The following is a description of a gene set: Mouse Gene Set: GOMF_DNA_BINDING_TRANSCRIPTION_FACTOR_ACTIVITY A transcription regulator activity that modulates transcription of gene sets via selective and non-covalent binding to a specific double-stranded genomic DNA sequence (sometimes referred to as a motif) within a cis-regulatory region. Regulatory regions include promoters (proximal and distal) and enhancers. Genes are transcriptional units, and include bacterial operons. species: Mus musculus, and this is the list of marker genes: Nr1d2, Esx1, Hoxd13, Neurod6, Hivep3, Sohlh2, Hivep1, Hoxa13, Ppara, Foxn4, Zfp266, Erg, Sox12, Aebp1, Smad3, Gli2, Hoxb6, Zfp296, Pbx1, Figla, Prdm16, Zfp182, Zfp772, Zfp941, Klf2 (NCBI Gene Id 16598), Isl1, Rslcan18, Zeb1, Foxe3, Pparg, Rhox2c, Twist1, Zhx1, Dlx1, Six3, Pbx3, Zscan29, Pou3f4 (POU domain, class 3, transcription factor 4), Csrnp1, Zfp442, Usf1, Rbpjl, Zfp451, Rfx5, AI854703, Hoxa11, Zbtb7c, Sox13, Myef2 (myelin basic protein expression factor 2, repressor), Gtf2i, Zfp729a, Zbtb25, Tbx6, Sp2 (NCBI Gene Id 78912), Relb, Zfp935, Rxrb, Scx, Cebpd, Olig3, Bhlha9, Zfp87, Hesx1, Mef2c, Hoxd10, Alx1, Tead4, Snai2, B020011L13Rik, Zfp148, Tcf7l1, Zfp872, Lbx1, Lef1, Arid3c, Zfp518a, Ar, Zfp395, Ovol3, Sp8, Onecut1, Elf2, Nfatc1, Hmx1, Zfp696, Pgr, Purg, Zfp322a, Nfe2 (nuclear factor, erythroid derived 2), Tcerg1, Ecsit, Irf2, Mnt, Dach1, Mecom, Pou3f1, Zfp472, Rela, Litaf, Uncx, Zfp973, Zfp773, Zfp1007, Ebf3 (NCBI Gene Id 73115), Bach1, Zfp790, Trp63, Gm10033, Batf3, Crebl2, Nr6a1, Foxc2 (NCBI Gene Id 14234), Zfp982, 4930522L14Rik, Fezf1, Zfp174, Atf5, Nr5a2, Zfp950, Esrrg, Tcf3, Zfp747, Rhox1, Rhox3g, Neurog1, Nkx2-6, Egr2, Sohlh1, Zeb2, Ikzf3, Neurog2, Stat6, Nkx6-1, Ebf1, Osr1, Tfe3 (transcription factor E3), Gm14443, Tead3, Hif3a, Mycl, Gm14322, Zic4, Zfp2, Zfp871, Preb, Hand2, Mycs, Prdm5, Klf1, Zfp784, Dmrta2, Zfp710, Gm19965, Zfp39, Smad9, Zfp110, Rfx7, Stat5a, Atf2, Ncoa3, Gm14418, Myog, Zim1, Dmrtc1a (NCBI Gene Id 75663), Drgx, Onecut3, Mxi1, Satb2, Sim2, Zfp566, Zfp692, Foxo3 (NCBI Gene Id 97633), Runx1, Zfp24, Zfp764, Dmtf1l, Sox8, Zfp712 (NCBI Gene Id 78251), Zscan26, Meox1 (mesenchyme homeobox 1, NCBI Gene Id 17285), Kmt2d, Klf16, Zbtb1, Gm17655, Msx2, Foxn3, Zfp369, Phox2b, Zbtb2, Duxf4, Hsf2, Zfp189, Etv3, Gcm1, Thap1, Glis3, Sall2, Gli3, Zfp534, Sall1, Pou3f2, Foxh1, Stat2, Vsx1, Rpf2, Foxg1, Rfx8, Zfp456, Satb1, Nacc1, Zfp980, Zfp791, Klf14, Cdc5lrt10, Ascl2, Zfp184, Pou4f2, Zfp317, Aff1, Nr1h5 (NCBI Gene Id 381463), Gpbp1, Zfp683, Carf, Bnc1, Zfp382, Gsx1, Shox2, Zbtb4, Lhx4, Zscan10 (zinc finger and SCAN domain containing 10), Ets2, Sp110, Cc2d1b, Zfp524, Tcf23 (transcription factor 23), Ctcf, Tlx1, Rhox7b, Samd11, Sry, Zbtb3, Rbpj, Zfp560, Meis1, Obox1, Spz1, Zscan4-ps1, Isx, Zfp287, E4f1, Zbtb9, Irf7, Rxrg, Plag1, T, Zfp998, Zfp9, Foxl3, Thra, Zfp934, Mef2b, Zfp729b, Zfp423, Zfhx3 (zinc finger homeobox 3), Foxd3, Zfp992, Prrx2, Irf8, Otx1, Hdac5, Zkscan5, Esrra, Tbx5, Sp140l1, Zfp438, Zfp160 (NCBI Gene Id 77146), Zfp14, Zfp607a, Gm3604, Zic1, Obox2, Zfp979, Ets1, Zfp1, Purb, Prrx1, Zfp58 (NCBI Gene Id 238693), Atf6b, Dbx1, Otx2, Creb3l2, Rreb1, Jdp2, Nfix, Zfp930, Tfap2e, Rarg, Rsl1, Neurod4, Nr3c1, E2f2, Hoxc4, Skil, Sp140l2 (Sp140 nuclear body protein like 2), Foxe1, Sox30, Pou6f1, Plscr1, Nkx6-3, Zfp101, Zfp68, Bcl11a (BCL11 transcription factor A), Trps1, Zfp641, Dmrt1, Notch2, Zkscan17, Samd7, Zfp386, Zfp981, Lhx1, Lhx6, Egr3, Zfp758, Gata4, Pura, Junb, Zfp507, Barhl1, Zfp746, Hoxa7, Gm14434, Sox15, Zik1, Npas4, Vax2, Rhox11, Foxk2, Helt, Ikzf4 (NCBI Gene Id 319294), Crxos, Cebpg, Zfp966, Sox6, Mesp1, Zfp867, Mafk, Mypop, Tgif2, Sp4, Zfp563, Pasd1, Sp3, Zfp740, Obox8, Tfdp2, Gata6 (NCBI Gene Id 14465), En2, Zfp582, Mxd1, Pax5, Myrfl, Cphx1, Nkrf, Nkx2-3, Epas1, Tfec, Sp6, Zscan4c, Sox4, Zfp667, Insm1, Hlx, Prdm1, Zscan4d, Tshz2, Ski, Sox14, Zfp273, Zfp819, Nfyc, Gm14325, 2810021J22Rik, Tbx4, Thrb, Zfp105, Zfp239, Rel, P2rx2, Creb3, Fezf2, Zkscan16, Fosl1, Zfp551, Cdx2, Usf3, Zfp637, Dmrt2, Tbx21, Zfp146, Egr1, Vdr, Sall3, Zbtb10, Dbp, Zfp946, Pitx3, Hif1a, Nrf1, Dlx2, Zfp512b, Nkx6-2, Nr1h2, Prdm11, Nfkb2, Rhox3a, Klf10, Olig2, Prdm2, Bmal1, Zfp446, Foxf1, Ebf4, Foxr1, Skor1, Zfp1004, Smad2, Dmrta1, Sox2, Zfp623, Zbtb46, Zfp280b, Tcf7, Gata2, Creb1, Zfp354b, Mnx1, Zfp697, Lbx2, Mixl1, Atf4, Foxp4, Nr4a2, Nkx1-2, Ascl4, Irf6, Zbtb47, Patz1, Rhox4b, Nkx2-2, Hoxa2, Zfp513, Zfp952, Gm6871, Hoxa4, Zfp516, Bhlhe40, Klf17, Zfp213, Zkscan1, Hoxb3, Npas3, Hdx, Sox10, Atf6, Zfp971, Ahr, Gm14403 (NCBI Gene Id 433520), Zfp763, Zfp212, Tfcp2l1, Meis2 (NCBI Gene Id 319479), Zfp169, Zfp985, Foxl1, Zfp384, Batf2, Irx1, Zscan4e, Barx2, Mkx, Zfp963, Hoxb2, Bmal2, Myrf, Zfp418, Zc3h8, Irf5, Zfp870, Zbtb11, Arnt, Cdc5lrt5, Zfp41, Zfp954, Zfp959, Zbtb14, Gm4767, Jun, Alx4, Zfp28, Xbp1, Zbtb40, E2f7, Foxj2, Nfe2l3, Foxs1, Foxq1, Nr1h4, Jph2, Irf3, Rhox4c, Zfp644, Zbtb6, Or51e2, Hmx3, Arap1, Pou5f2, Gmeb1, Zbtb39, Sp5, Zfp217, Ehf, Zfp444, Hoxd3, Zscan5b, Pknox1, Deaf1, Hoxb13, Prdm14 (PR domain containing 14), Skor2, Cdc5lrt9, Pou3f3, Mrtfb, Zfp777, Tfeb (transcription factor EB), Rarb, Gm14401, Tfap2b, Zfp366, Hoxc13, Zfp128, Noto, Rhox4e, Dmrtb1, Glis1, Pax4, Neurod1, Hnf4a, Cdc5lrt4, Stat5b, Zfp383, Vax1, Foxa3, Zfp72, Nfatc2, Hoxa1, Csrnp2, Rlf, Fosb, Fli1, Tbx19, Maz, Nr4a1, Zfp493, Zfp263, Zfp821, Zfp113, Ylpm1, Zfp991, Zbtb49, Pou2f3, Zfp809, Zfp286, Foxf2, Sox17, Gtf2ird1, Grhl3, Creb3l1, Zkscan3, Tfap2c, A630001G21Rik, Rxra, 2010315B03Rik, Evx1, Gmeb2, Tbx22, Rara, Zfp568, Glis2, Mlxipl, Lhx3, Mycn, Zbtb42, Zfp175, Esr2, Duxbl1, Casz1, Atmin, Zhx3, Zscan4f, Nhlh1 (NCBI Gene Id 226661), Scrt2, Zfp397, Dmbx1, Nobox, Ascl3 (achaete-scute family bHLH transcription factor 3), Mynn (myoneurin), Csrnp3, Bcl11b, Zfp961, Zfp846, Mafb, Zfp707, Tbx1, Zfp599, Snai1, Zic5, Foxd4, Usf2 (upstream transcription factor 2, NCBI Gene Id 22282), Sall4, Lhx2, Zfp955b, Zfp69, Myt1, Zfp420, Irx5, Ascl1, Nkx2-1, Rhox7a, A430033K04Rik, Neurod2, Nr2f2, Pbx2, Tlx2, Zfp873, Peg3, Rhox4a, Irf1, Zbtb12, Tal1, Zfp704, Hes1, Nanog, Etv6, Snai3, Klf4, Trp73, Nkx3-2, Pde3a, Foxp1 (forkhead box P1), Zfp324, Hnf4g, Irx4 (Iroquois homeobox 4), Twist2, Zfp616, Mtf1, Erfl, Ikzf2, Zfp251, Brca1, Barhl2, Ovol1, Zscan25 (zinc finger and SCAN domain containing 25), Gcm2, Elf3, Nkx1-1, Hoxb9, Cdc5lrt6, Zfp708, Dach2, Zfp82, Zfp951, Pou4f3, Nr2f6 (NCBI Gene Id 13864), Prop1 (NCBI Gene Id 19127), Zfa-ps, Spib, Dlx5, Zfp90, Zfy1, Zbtb7a, Adnp, Zfp647, Emx1, Zfp280c, Foxc1, Plagl2, Hsf5, Arx, Zfp1005, Tbx15, Zfp747l1, Zfp617, Ikzf5, Nhlh2, Ddn, Zfp275, Zfp995, Hoxc8, Zfp799, Otp, Six1, Klf15, Cux2, Zfp354c, Zfp709, Lhx8, Nr2c2, Phox2a, Nr1d1, Zscan22, Tbx10, Zfp334, Zscan12, Zfp85, Hoxd9, Zfp518b, Nfyb, Rfx1, Nfatc4, Sp9, Zfp868, Etv5, Cdx1, Zfp668, Zfp976, Atf3, Zbtb34, Zfp944, Plagl1, Prdm10, Zscan21, Maff, Rhox8, Mef2a, Zfp994, Maf (MAF bZIP transcription factor), Six6, Erf, E2f5, Zfp157, Rfx3, Zfp457, Atoh1, Zfp455, Etv3l, Hoxc10, Atoh8, Rora, Zic3, Zkscan4, Rhox10, Zscan4-ps2, Bmyc, Ddit3, Zfp850 (zinc finger protein 850), Zfp84, Hey1, Plscr2, Zbtb8b, Rhox12 (NCBI Gene Id 382282), Rhox3h, Zfp3, Foxn2, Sox21, Zbtb26, Hoxc11, Lmx1a, Lyl1, Prox2, Rest (RE1-silencing transcription factor), Zfp408, Zfp280d, Nacc2, Gm14391, Klf5, Nr5a1 (nuclear receptor subfamily 5, group A, member 1), Foxj1, Hes5, Men1 (NCBI Gene Id 17283), Zbed4, Zfp931, Hoxc5, Esr1, Tcf15 (NCBI Gene Id 21407), Tal2, Elf1, Zfp367, Zfp42, Yy2, Crebrf, Evx2, Foxd2, Nfia, Pax3 (NCBI Gene Id 18505), Tcfl5, Zfp964, Zkscan7, Zfp292, Zfp575, Cebpb, Etv4, Zfp141, Zfp810, E2f4, Zfp345, Tshz1 (NCBI Gene Id 70498), Lhx5, Zfp960, Max, Esrrb, Foxi3, Zfp580, Hic1, Zfp677, Tbx3, Spi1, Zfp639, Zfp1006, Zfp865, Zfp597, Zfp202, Zfp260 (NCBI Gene Id 26466), Zfp426, Hbp1, Hinfp, Zfp281, Clock, Tbx18, Tef, Zfp879, Rhox6, Bsx, Spen, Mafa, Zfp449, Gsc, Sox7, Crebzf, Tcf7l2, Rhox4g, Creb5, Zbtb37, Myf6, Mafg, Hoxb8, Trp53, Stat4, Zfp825, Six2, Nr2f1, Nfx1 (NCBI Gene Id 93788), Zbtb21, Zkscan2, Cc2d1a, Zbtb45, Sp100, Gm5141, Zfp12, Zfp664, Nkx2-9, Klf11, Klf7, Aff3, Msx1, Elk1, Tead2, Zbed6 (NCBI Gene Id 675760), Zfp579, Nfxl1, Tfap4, Yy1 (YY1 transcription factor), Crx, Zfp975, Hoxa10, Zfp53, Runx2, Mlxip, Etv2, Cdx4, Zfp119a, Cdc5lrt1, Pax2, Zfp454, Zbtb38, Zfp655, Hoxc9, Fev, Foxo6, Lmx1b, Nr2e3, Alx3, Rhox3c (reproductive homeobox 3C), Zfp352, Cdc5lrt7, Hnf1a, Sox11, Creb3l3, Emx2, Zfp874b, Lrrfip1, Nkx3-1, Zfp672, Npas1, Obox6, Myt1l, Meis3 (Meis homeobox 3), E2f3, Hoxb7, Gm45871, Sox3, BC024063, Zfp764l1, Nr2e1, Zscan20, Mga, E2f8, Hoxb5, Nr1h3, Npas2, Pou2f2, Rhox9, Klf13, Atoh7, Dmrt3, Notch1, Klf12, Zfp654, AU041133, Foxo1 (NCBI Gene Id 99758), Zfp715, Rhox2d (NCBI Gene Id 634407), Rfx4, Hoxa9, Zfp78, Atf7, Insm2, Foxl2, Srf, Cdkn2a, Rhox3f, Jund, Zfp719, Tead1, Ferd3l, Paqr8, Rfx6, Msgn1, Hmx2, Mlx, Klf9, Tfdp1, Nr1i3, Zfx, Hey2, Ahdc1, Smad4, Zfp7, Zfp983, Zfp119b, Pbx4, Fos, Nr3c2, Pcbp1, Rhox13, Rhox2a, Rex2, Zfp775, Zfhx2, Hoxd4, Zscan4b, Irf4, Olig1, Tcf12, Zfp125 (zinc finger protein 125), Irx2, Gfi1b, Foxm1, Six4, Grhl1, Pax9, Cdc5l (NCBI Gene Id 71702), Gm2381, Myb, Zfp955a, Zfp711, Rorc, Zbtb17, Hdgf, Nr4a3, Zfp219, Zglp1, Foxb2, Zfp59, Homez, Foxn1, AI987944, Sox5, Myod1, Gm14412, Zfp988, Cic, Foxo4, Zfp626, Zfp612, Zfp947, Cebpa, Pdx1, Zfp787, Rhox2b, Hoxa6, Heyl, Bach2, Zfp607b, Zfp120, Rfxank, Duxf3, Hes3, Rbak, Zfp874a (NCBI Gene Id 238692), 5730507C01Rik, Ciao1, Tbx20, Six5, Zfp37, Zhx2, Ss18l1, Sp1, Zfp54, Msc, Tfap2a, Zfp938, Thap11, Zfp316, Zkscan14, Zbtb8a, Rorb, Scrt1, Rax (NCBI Gene Id 353033), Mybl2, Foxj3, Dmrtc2, Isl2, Nrl, Gsc2, Gm35315, Tcf4, Zfp853, Zfp768, Dlx3, Eomes, Zfp429, Eno1, Wiz, Gm7072, Zfp942, Dmrtc1b, Tgif1 (TGFB-induced factor homeobox 1), Etv1, Zfat, Zfp866, Gzf1, Hoxc6 (homeobox C6), Mxd4, Stat1, Onecut2, Srebf1, Foxi1, Bcl6, Gfi1, Lhx9, Ctcfl, Zfp652, Zbtb43, Paqr7, Elk4, St18, Cux1, Pknox2, Zfp536, Gabpa, Hoxb1, Creb3l4, Cdc5lrt8, Zfp869, Klf6, Ahrr, Nkx2-5, Zbtb48 (zinc finger and BTB domain containing 48), Mitf, Ascl5, Zbtb16, Zfp30, Hivep2, Zkscan8, Foxr2, Pitx1, Foxi2, Bcl6b, Ovol2, Pax6, Elf5 (NCBI Gene Id 13711), Hsf3, Zfp354a, Tshz3, Barx1, Zbtb33, Hoxd11, Myc, Prox1, Myf5, Tbr1, Grhl2, Bhlhe23, Foxb1, Egr4, Fosl2, Zfp13, Nfic, Zfp977, Zfp750, Atf1-ps, Foxa1, Gm12258, 2610008E11Rik, Bbx, Zfp932, Stat3, Zfp92, Tlx3, Zfp523, Zbtb18, Elk3, Nfib, Zfp97, Rhox2g (NCBI Gene Id 434766), Batf, Rhox4f, Hoxb4, Msx3, Zfp882, Zfp358, Tfcp2, Obox3, Rhox5, Zkscan6, Dmtf1, Zfp65, Hoxd1, Irx3, Nr1i2, Gper1, Osr2, Nfat5, Sox1, Bhlhe41, Zfp943, Smad5, Zscan2, Foxk1, Zfp46, Zbtb24, Mybl1, Gm32687, Zfhx4, E2f1, Zfp937, Mesp2, Nfe2l1, Foxp3, Zfp984, Klf3, Zfp410, Sox9, Gata1, Hand1, E2f6 (E2F transcription factor 6), Zfp583, Neurog3, Hoxd8, Zfp236, Rhox2h, Irx6, Zfp398, Pax8, Nr2c1, Zfp990, Hnf1b, Nkx2-4, Dlx6, Zfp820, Spic, Elf4, Zbtb22, Gsx2, Zfp433, Zfp180, Hes6, Dlx4, Hsf1, Smad1, Irf9, Foxa2 (NCBI Gene Id 15376), Mxd3 (Max dimerization protein 3), Zfp74, Obox5, Hic2, Zfp329, Gbx2, Wt1 (WT1 transcription factor), Gbx1, Hlf, Abhd2, Zfp248 (zinc finger protein 248), Zfp1010, Zfp691, AW146154, Kcnip3, Zbtb32, Mrtfa, Zfp958, Zgpat, Eno1b, Hoxc12, Zfp648, Mzf1, Zfp933, Obox7, Zfp970, Zic2, Rfxap (NCBI Gene Id 320768), Cebpe (NCBI Gene Id 239097), Gli1, Zbtb20, Sim1, Dmrtc1c1, Zfp663, Pax7, Platr25, Hhex, Zfp143, Zfp956, Arnt2, Pou4f1, Prdm4, Runx3, Pitx2, Rhox2f, Gata5, Crem, Nfatc3, Ubp1, Zfp940, Zfp362, En1, Srebf2, Pou5f1, Pou1f1, Gm15446, Ebf2, Atf1, Vezf1, Ptf1a, Zfp558, Zfp989, Zfp949, Hoxd12, Gata3 (GATA binding protein 3), Hoxa3, Hes7 (hes family bHLH transcription factor 7), Ikzf1, Pax1, Foxp2, Zfp689, Sox18, Klf8, Pou6f2, Zscan4-ps3, Gm4924, Zfp459, Zfp997, Mef2d, Rhox4d, Zfp628, Hoxa5, Nfya, Nfil3, Hes2, Nfe2l2, Zfp81, Zfp341 (zinc finger protein 341), Zfp131, Zbtb5, Gm14444, Zbtb7b, Ppard, Meox2, Tbx2, Bhlha15, Spdef, Foxd1, Nfkb1, Tcf24, Zbtb41, Pou2f1 (NCBI Gene Id 18986), Rfx2, Tcf21, Sp7, Bhlhe22, Gm14399, Hsf4, Vsx2, Zfp987, Notch4, Zfp811, Tfap2d